Given this list of marker genes TXNL1, ACTG1, TRA2B, HSP90AB1, SRRM1, CUL3, CDC37, RHOBTB2, DBN1, MYO6, RBMX, TMOD3, HSP90AA1, TWF1, DDX39B, STK38, CCT6A, PHIP, HNRNPC, MSI2, ACTN1, CCT7, CCT2, here is a description of the gene set: RHOBTB2 is an atypical member of the RHO GTPase family that is predicted not to cycle between a GTP-bound form and a GDP-bound form. RHOBTB family proteins, in contrast to other RHO GTPases, possess other conserved domains in addition to the GTPase domain. The GTPase domain at the N terminus is followed by a proline rich region, a tandem of two BTB (broad complex, tramtrack, bric à brac) domains, and a conserved C terminal BACK (BTB and C terminal Kelch) domain. RHOBTB proteins can form homo- and heterodimers, but the role of dimerization in RHOBTB function is not known. RHOBTB2 is usually expressed weakly, at a lower level than RHOBTB1. Relatively high levels of RHOBTB2 can be detected in neural and cardiac tissues. RHOBTB2 is involved in COP9 signalosome-regulated and CUL3-dependent protein ubiquitination. RHOBTB2 suppresses cellular proliferation and promotes apoptosis. RHOBTB2 takes part in vesicle transport. RHOBTB2 was initially discovered as the gene homozygously deleted in breast cancer and was named DBC2 (deleted in breast cancer 2). RHOBTB2 level is decreased in many tumor types and it is proposed to act as a tumor suppressor. Genomic deletions and a small number of pathogenic mutations in RHOBTB2 have been reported in cancer. Mutations of RHOBTB2 that result in impaired interaction with CUL3 have been found to cause epileptic encephalopathy. Reactome Pathway: RHOBTB2 GTPase cycle part of: RHOBTB GTPase Cycle species: Homo sapiens